Given this list of marker genes DUSP10, DUSP2, BRAF, DUSP9, KSR1, PPP2CA, MAP2K2, PTPN7, NRAS, DUSP5, PPP2CB, MARK3, HRAS, PAQR3, DUSP7, DUSP16, MAPK3, UBA52, ARAF, RPS27A, DUSP1, PPP2R5E, MAP2K1, PPP2R5B, DUSP4, PPP2R5D, MAPK1, DUSP6, KRAS, PPP2R1A, PPP2R5A, PPP2R5C, PTPN3, DUSP8, MAPK12, UBC, UBB, PPP5C, PEBP1, YWHAB, BRAP, RAF1, PPP2R1B, here is a description of the gene set: species: Homo sapiens The duration and extent of activated MAPK signaling is regulated at many levels through mechanisms that include phosphorylation and dephosphorylation, changes to protein interacting partners and subcellular localization. <br><br>Activated RAF proteins are subject to MAPK-dependent phosphorylation that promotes the subsequent dephosphorylation of the activation loop and NtA region, terminating RAF kinase activity. This dephosphorylation, catalyzed by PP2A and PP5, primes the RAF proteins for PKA or AKT-mediated phosphorylation of residues S259 and S621, restoring the 14-3-3 binding sites and returning the RAF proteins to the inactive state (von Kriegsheim et al, 2006; Dougherty et al, 2005; reviewed in Matallanas et al, 2011). The phosphorylated RAF1 NtA is also subject to additional regulation through binding to the PEBP1 protein, which promotes its dissociation from MAP2K substrates. <br><br>Activated MAPK proteins also phosphorylate T292 of MAP2K1; this phosphorylation limits the activity of MAP2K1, and indirectly affects MAP2K2 activity through by modulating the activity of the MAP2K heterodimer.<br><br>Dephosphorylation of MAPKs by the dual specificity MAPK phosphatases (DUSPs) plays a key role in limiting the extent of pathway activation. Class I DUSPs are localized in the nucleus and are induced by activation of the MAPK pathway, establishing a negative feedback loop, while class II DUSPs dephosphorylate cytoplasmic MAPKs.<br>MAPK signaling is also regulated by the RAS GAP-mediated stimulation of intrinsic RAS GTPase activity which returns RAS to the inactive, GDP bound state. Reactome Pathway: Negative regulation of MAPK pathway part of: RAF/MAP kinase cascade